The following is a description of a gene set: Human Gene Set: REACTOME_ACTIVATION_OF_GENE_EXPRESSION_BY_SREBF_SREBP Activation of gene expression by SREBF (SREBP) species: Homo sapiens, and this is the list of marker genes: MTF1, PPARA, IDI1, SQLE, CREBBP, TM7SF2 (transmembrane 7 superfamily member 2), HELZ2, CYP51A1 (cytochrome P450 family 51 subfamily A member 1), FDFT1 (NCBI Gene Id 2222), MVK, HMGCS1, NCOA2, NFYC, RXRA, MVD, SREBF2, FDPS, ACACB, ACACA, NCOA6, DHCR7, PMVK, SP1, ELOVL6, TBL1X, NCOA1, NFYB, CARM1, SC5D, CHD9, GPAM, LSS, GGPS1, TGS1, MED1, SMARCD3, SREBF1, SCD, HMGCR (3-hydroxy-3-methylglutaryl-CoA reductase), FASN, TBL1XR1, NFYA